The following is a description of a gene set: species: Homo sapiens Human Gene Set: VERNELL_RETINOBLASTOMA_PATHWAY_UP Deregulation of the retinoblastoma protein (pRB) pathway is a hallmark of human cancer. The core members of this pathway include the tumor suppressor protein, pRB, which through binding to a number of cellular proteins, most notably members of the E2F transcription factor family, regulates progression through the cell division cycle. With the aim of identifying transcriptional changes provoked by deregulation of the pRB pathway, we have used cell lines that conditionally express a constitutively active phosphorylation site mutant of pRB (pRBDeltaCDK) or p16INK4A (p16). The expression of pRBDeltaCDK and p16 resulted in significant repression and activation of a large number of genes as measured by high density oligonucleotide array analysis. Transcriptional changes were found in genes that are essential for DNA replication and cell proliferation. In agreement with previous results, we found a high degree of overlap between genes regulated by p16 and pRB. Data we have obtained previously for E2F family members showed that 74 of the genes repressed by pRB and p16 were induced by the E2Fs and genes that were induced by pRB and p16 were repressed by the E2Fs. Thus, we have identified genes as physiological targets of the pRB pathway, and the further characterization of these genes should provide insights into how this pathway controls proliferation. We show that Gibbs sampling detects enrichment of several sequence motifs, including E2F consensus binding sites, in the upstream regions of these genes and use this enrichment in an in silico filtering process to refine microarray derived gene lists. Cluster 1: genes up-regulated by RB1, CDNK2A, and one of the E2Fs (E2F1, E2F2, or E2F3). from publication Vernell R, Helin K, Müller H (PMID 12923195), and this is the list of marker genes: KLHL42, RMI1, ASF1B, MCM8, HUNK, EPS8, DONSON, MCM7, FAM161A, SPIN4, ZNF367, CDCA5, UBR7, VRK1, TFDP1 (transcription factor Dp-1), EGR1, RRM1, FST, RFC4, RAD51AP1, PBX3, BARD1, MANEAL (mannosidase endo-alpha like), HMGB2, PTX3, SKP2, TMEM97, E2F2, CDCA4, PCNA, MELK, FANCA, TCF19, CHAF1A, RRM2, BTG3, SNTB2, JPH1, SUZ12, SLBP, MCM4, DCK, KANK2, CDKN1A (NCBI Gene Id 1026), DEK, CCNE1, CDC25A, FBXO5, ATAD2, RAB27A, CDCA7L, KCNK1, CNOT6L, EZH2, FAM111A, ESCO2, HACD3, RECQL4 (NCBI Gene Id 9401), POLD3, MCMBP, CENPK, BLM, RFC3, TMPO, EED, FEN1, CLSPN, HAUS1, NPAT